The following is a description of a gene set: species: Mus musculus Mouse Gene Set: chr18E3, and this is the list of marker genes: Gm19062, Gm41793, Gm26012, 4930445N18Rik (RIKEN cDNA 4930445N18 gene), Loxhd1, Gm50351, Gm26014, Haus1, Atp9b, Gm20593, Zbtb7c, Rbfaos, Gm8807, Pard6g, Gm30288, B020010K11Rik, Slc14a1, Gm26676, 4930592I03Rik, 4933401L05Rik, 4931439C15Rik, Gm7569, Hdhd2, Smad2, Gm46620, Gm7276, Gm25824, Zfp516 (zinc finger protein 516), Gm23895, Gm18910, Skor2, Galr1, Slc66a2, Gm17383, Zfp236, 1700034B16Rik, Sall3, Gm30454, Gm9028, Gm30593, Setbp1, Gm5509, Gm7447, Gm18978, Gm36627, D330025C20Rik (RIKEN cDNA D330025C20 gene), 2900057B20Rik, Ctdp1 (CTD phosphatase subunit 1), Atp5f1a, Gm6133, Ark2c, Gm46614, Gm36718, Ctif, Gm46629, 1700003O11Rik, Gm30889, Naa12, Ark2n, Gm41792, Gm10524, Ier3ip1, Smad7, BC026513, AA684185, 2010010A06Rik, Gm2176, Gm31265, Gm31933, Kcng2, Gm26977, Gm10532, Adnp2, 4921531P14Rik, Mir5127, Gm7503, Pias2, Gm31503, 4930594M17Rik, Epg5, Slc14a2, Mir6358, Txnl4a, Rbfa, 1700095A13Rik, Gm20544, Siglec15, Gm20570, 2210420H20Rik, Rpl21-ps8, Gm5823, Gm27239, Mir5112 (NCBI Gene Id 100628586), A330094K24Rik, Katnal2 (katanin p60 subunit A-like 2), Pstpip2 (proline-serine-threonine phosphatase-interacting protein 2), Hsbp1l1, Nfatc1, Gm30192, Mbp, Gm2116, Gm41790 (predicted gene, 41790), Gm25718, F830208F22Rik, Gm41787, St8sia5